The following is a description of a gene set: studied in species Mus musculus part of: Calmodulin induced events Reactome Pathway: Cam-PDE 1 activation This event has been computationally inferred from an event that has been demonstrated in another species.<p>The inference is based on the homology mapping from PANTHER. Briefly, reactions for which all involved PhysicalEntities (in input, output and catalyst) have a mapped orthologue/paralogue (for complexes at least 75% of components must have a mapping) are inferred to the other species. electronically inferred by orthology from the curated human pathway, and this is the list of marker genes: Calm1, Pde1b, Pde1c